The following is a description of a gene set: species: Homo sapiens A transcription termination process that completes the production of a primary RNA polymerase II transcript. Human Gene Set: GOBP_TERMINATION_OF_RNA_POLYMERASE_II_TRANSCRIPTION, and this is the list of marker genes: PPP1R10, PPP1CA, MAZ, SSU72L3, SSU72, SETX, SCAF4, WNK1, SSU72L1, SCAF8, SSU72L4, SSU72L5, PCF11, SSU72L6, XRN2, TTF2, SSU72L2